Given this list of marker genes ITM2B, EIF2B5, VAV1, CSF1R, SLC25A1, SPG7, BTD, GRAMD4, MCM5, MAPK3, CMTR1, OS9, HIRA, TRAPPC6A, PLXND1, MYO9B, PLD2 (NCBI Gene Id 5338), TECR, CPSF1, TSC2, MAU2, DDB1, ARSA, WBP1L, EPHX1, TP53TG1, PECAM1, SLC7A8, IFFO1, ST8SIA4, SART1, IL10RB, ATP9B, RENBP, CAMK1, ALDH6A1, MVD, CTSA, CUX1, UBTF, CPVL, ATP6V0C, PTGIR, GDI1, MAN2C1, RAB5C, PFKFB3, CST3, GDF11, HNMT, ARRB2, SLC43A1, PCSK7, HADHA, ZNF428, ATP6V0A1, IDH2, SNN, DGKZ, GSTP1, MLEC, JPT2, RAB4A, NAGLU, CACTIN, LRP10, ARHGEF6, OAS2, RBP1, TBC1D9B, RGS19, DAP, FAM89B (NCBI Gene Id 23625), TBC1D2B, INTS9, ACP5, IGF1, POLE, CD302, ANAPC15, MMUT, NISCH, BTBD2, MAN2B1, GATM, NAGPA, GPSM3, ENG, PPIL2, SUPT5H, ZNF185, RAB11B, PLCB3, RB1, SUPT6H, ATRN, FASN, CD4, TSPAN4, FOLR2, NUCB1, CMKLR1, GCDH, R3HCC1, BCKDHB, HDAC6, STXBP2, MEA1, BAG6, P2RY6, WBP2, ARFIP2, FMO5, ARAP1, ASCC2, GAS7, TPP1, AGRN, VPS11, LZTR1, ZFPL1, STAB1, PLXNC1, SGSH, TXN2, TSR3, LSM2, GBF1, TERF1, FCGRT, SORBS3, VPS52, BLVRB, ZZEF1, SELENOP, MLF2, TMEM259 (transmembrane protein 259), ENTPD6, EPHB2, FCGBP, TNFAIP2, HEXA, FAM3A, BSG, PIP5K1C, ERP29, RNASE6, GABARAP, SF3A1, HSD17B8, CLEC11A, MAP2K2, POR, CLPTM1, PRPF8, RHOG, RHBDD3, DENND4B, ZBTB48, ZBED1, RAB4B, FLAD1, AP2B1, PLD3, TADA3, SCD, PRPF6, LTBR, ZNF710, PMF1, MEGF8, BTK, RANGAP1, TRIM28, ZYX (NCBI Gene Id 7791), RPS6KA2, GRN, ADORA3, ATXN7L3B, GAA, TRADD, ARHGAP4, SH3GL1, MAZ, B3GALT4, GNPDA1, ERAL1, MYO1F, TIMP2, PRKCSH, TFE3, SLC4A2 (NCBI Gene Id 96677), NCF4, ERGIC3, IKZF1, MAP3K11, RTN1, RNF40, TBXAS1, KCNAB2, here is a description of the gene set: from publication Croker BA, Krebs DL, Zhang JG, Wormald S, Willson TA, Stanley EG, Robb L, Greenhalgh CJ, Förster I, Clausen BE, Nicola NA, Metcalf D, Hilton DJ, Roberts AW, Alexander WS (PMID 12754505) studied in species Homo sapiens Genes down-regulated in liver from SOCS3 knockout: untreated versus IL6 injection. Human Gene Set: GSE369_PRE_VS_POST_IL6_INJECTION_SOCS3_KO_LIVER_DN Changes in mouse liver mRNA profiles following intraperitoneal cytokine injection. Either interferon-gamma-/-, albumin-cre(-) Socs3(w/fl) mice, or albumin-cre(+) Socs3(-/fl) mice were injected with either phosphate-buffered saline, interferon-gamma, or interfeukin-6, and livers taken after 4h.